The following is a description of a gene set: Human Gene Set: GOBP_LATE_ENDOSOME_TO_GOLGI_TRANSPORT studied in species Homo sapiens The directed movement of substances from late endosomes to the Golgi., and this is the list of marker genes: RAB7B, GCC2, SNX12, AP5Z1, SNX3, SGSM2